The following is a description of a gene set: Human Gene Set: GOMF_VOLTAGE_GATED_CALCIUM_CHANNEL_ACTIVITY Enables the transmembrane transfer of a calcium ion by a voltage-gated channel. A voltage-gated channel is a channel whose open state is dependent on the voltage across the membrane in which it is embedded. studied in species Homo sapiens, and this is the list of marker genes: CACNB2, PKD2, CACHD1, CACNA1D, CACNA1G, CACNG2, TPCN2, CACNA1C, CACNA1H, CACNA1I, CACNA1S, TRPA1, CACNA1A, TMC2, RYR1, CACNA2D3, CACNG3, CACNA1E, CACNA2D1, CACNB4, CACNG4, CACNG1, CACNG6, CACNB1, TMC1 (NCBI Gene Id 53634), CACNG7, TSPOAP1, NCS1, CACNA1B, CATSPER3, CATSPER4, CALHM1, TRPV1, ITGAV, CATSPER1, CACNA2D2, CACNA2D4, CATSPER2, CACNB3, CACNG8, OPRM1, CACNG5, CACNA1F